Given this list of marker genes ARB2A, NMNAT1, ARHGAP42, BCL7B, PEX11A, SOCS2, TAF7, XKR7, MIB1, SIX5, SSPN, MAP7, TTPAL, ACER3, PSIP1, SCN3A, CA2, FMN2, MGARP, TERB2, MITF, DNAJC27, ONECUT2, PLAC1, PPP6R3, PHEX, PIP4P2, ANKRD42, RORA, KLHL7, PAX5, CALD1, CAB39, SREK1, KCNJ14 (potassium inwardly rectifying channel subfamily J member 14), NECAB2, SERPINB5, ABHD5, BPNT2, PAG1, MBNL3, CHIC1, GPD1L, ZEB1, PLEKHH3, SKIL, LPP, C1orf185, TRIM47, TXNDC16, ZNF793, KMT2A, HNMT, SREK1IP1, MED26, MAML3, COL19A1, ATRN, RYK, ATXN7, GDI2, TXLNB, PPP4R1, BRWD3, RSPO2, PRICKLE2 (prickle planar cell polarity protein 2), CCSER2, ZNF460, MYH10 (myosin heavy chain 10), CDH26, NCOA2, RND3, KIAA1958, NRARP, TRERF1, B3GLCT, RCAN1, PCGF3, CYTIP, C1QBP, TTLL7, PEDS1-UBE2V1, CYRIA, SH3BGRL2, LRCH2, APC, KLHL20, RNF24, RIMBP2, TEF, TMCO1, FRMPD4, HIVEP2, ALPL, PDK3, NFIB, VSTM2A, EIF2AK3, IPO8, GMNC, CADM2, RNF182 (ring finger protein 182), PLPPR1, KHDRBS2, FGF14, MTRF1L, AMD1, KDSR, BLOC1S6, SLC12A2, GABRP, ANKRD34C, RNF14, CRYM, KRT34, CREBRF, PTAR1, SAMTOR, CHURC1, RNF111, LAMC1, LCORL, PABPC1L2A, OOSP2, LGR4, CCNG1, FRS2, FICD, SYNPR, TP53INP2 (tumor protein p53 inducible nuclear protein 2), DHX29, ALG13, PRTG, CYFIP1, CENPK, GPN1, TNPO1, RAB10 (RAB10, member RAS oncogene family), ASTN2, THSD7A, CBLB, CUL3, NANOS1 (NCBI Gene Id 340719), HEATR6, SLC10A4, IKZF2, SEMA3C, PRKAB1, TRIM9, TRPS1, CABLES1, BCL11A, SYT9, STK32C, ANKS1B, RRP15, DLG5, ICMT, MINDY2, CA10, LARP7, HSPA4L, HOXA1, CELF1, TCAIM, KPNA1, LMNTD1, PPARGC1A, LRBA, PTPN21, SEC24D, SERINC5, MMRN1, NSG2, TSPAN12, CAP1, HSPA9, HOMER3, NCKAP5 (NCK associated protein 5), LHCGR, NID2, BOLA2-SMG1P6, RAP2C, TBC1D2B, TENM1, PTPRN, SENP6, KCNH8, CORO1C (NCBI Gene Id 23603), TFRC, BVES, CEP97, JPH4, XRN1, ATP6V0D2 (ATPase H+ transporting V0 subunit d2), DUSP16, ZNF681, DUSP18, FNDC3A, TMEM168, USP45, PRDX6, NMT2, TMEM38B, NETO2, CNTN1, RBM41, OSBPL8, ZNF552, RHOA, MTMR2, MAP10, INTS14, CASP8, RBAK, USF3, TCF12 (transcription factor 12), UBE2V1, TBL1X, DEFB118, CIAO2A, GIMAP1, SCAMP1, EIF4E, TMEM127, LIN28B, ZNF652, WDR76, MAP2K4, SGMS1, CDH6, USP49, NXF1, SEPTIN2, MUC15, CTDSPL, LRRC59, SDC4 (syndecan 4), GRAMD2A, RPS6KA6 (NCBI Gene Id 27330), LGI2, PABIR3, BMPER, SLC26A2, MED13L, GTF2H5, FAM76B, NAP1L4, GOLIM4, AHR (NCBI Gene Id 196), PSMA1, ZCCHC8, ANKRD44, NALF1, ABRAXAS2, RHOBTB3, RNF11, ZMAT4, CELF3, FPGT, ZNF131, MEMO1, PAK4, GIMAP4, ACTR3, LRP8, ZNF850, CRYBG3 (NCBI Gene Id 131544), DLG3, ANO5, ARSJ, KCND2, STRN3, CDK6, CATSPERB, ALG14, PRKCG, USP39, NHLRC2, PRKAR1A (protein kinase cAMP-dependent type I regulatory subunit alpha), GTPBP4, TEAD1, SRCIN1, ZCCHC2, SH3BP5, KCTD5, VWC2, here is a description of the gene set: Human Gene Set: MIR8067 from publication Chen Y, Wang X (PMID 31504780) species: Homo sapiens Genes predicted to be targets of miRBase v22 microRNA hsa-miR-8067 in miRDB v6.0 with MirTarget v4 prediction scores > 80 (high confidence targets).